Given this list of marker genes VPS72, BRD8 (NCBI Gene Id 10902), POTEE, MSL3B, KANSL1L, POTEI, PHF20L1, MEAF6 (MYST/Esa1 associated factor 6, NCBI Gene Id 64769), YEATS4 (YEATS domain containing 4), KANSL2, MORF4L2, MSL1, POTEJ, YEATS2, ACTBL2, KANSL3, MSL3, ING3, EPC2, ACTL8, RUVBL1, WDR5, OGT, ACTL6B, KANSL1, POTEF, EPC1, ACTG1, ACTB, HCFC1, ATF2, ACTL6A, MBTD1, RUVBL2, KAT8, KAT5, MORF4L1, TRRAP, POTEKP (POTE ankyrin domain family member K, pseudogene), MCRS1, MSL2 (MSL complex subunit 2), DMAP1, PHF20, EP400, MRGBP, here is a description of the gene set: A protein complex which is capable of H4 histone acetyltransferase activity. Human Gene Set: GOCC_H4_HISTONE_ACETYLTRANSFERASE_COMPLEX species: Homo sapiens